The following is a description of a gene set: Human Gene Set: GOBP_ETHANOLAMINE_CONTAINING_COMPOUND_METABOLIC_PROCESS The chemical reactions and pathways involving ethanolamine (2-aminoethanol) and compounds derived from it. studied in species Homo sapiens, and this is the list of marker genes: DBH, NAAA, GDPD1, NAPEPLD, MOXD1, GDE1, MOXD2P, GDPD3